Given this list of marker genes SYT13, CD151, MAPK8IP1, NRXN1, MS4A1, CD63, CLOCK, TSPAN18, B4GAT1, SPPL2C, FREY1, REST, LEF1, SLC35C1, CD82, B3GNT7, SDCBP, ITGA4, GLI3, ITGB2, NDST1, HBEGF, HLA-DMA, PEX3 (peroxisomal biogenesis factor 3), B4GALT4, HLA-DMB (NCBI Gene Id 3109, major histocompatibility complex, class II, DM beta), ITGA3, PEX16, IZUMO1, LARGE2, C11orf96, CRY2, PHF21A, TIMP1, CHST1, EXT2, SHH, HLA-DRA, TP53, ITGA6, CD53, LGALS3BP, CHST6, CD4, ACCS, ITGB1, ALKBH3, SLC25A17, CD19, VANGL1, ALX4, PRDM11, BMAL1, IGSF8, TP53I11, EXT1, here is a description of the gene set: species: Homo sapiens Human Gene Set: WP_11P112_COPY_NUMBER_VARIATION_SYNDROME 11p11.2 copy number variation syndrome